The following is a description of a gene set: studied in species Mus musculus Mouse Gene Set: GOCC_CONTRACTILE_MUSCLE_FIBER Fibers, composed of actin, myosin, and associated proteins, found in cells of smooth or striated muscle., and this is the list of marker genes: Rpl17, Myl4 (myosin, light polypeptide 4), Flnc, Sqstm1, Ak1, Tmod3, Nos1ap, Krt8 (keratin 8), Alppl2, Kcnj8, Ggps1 (NCBI Gene Id 97873), Palld, Kcnn1, Cmya5, Vcl, Kcna5, Cacna1d, Myl1, Prkd1, Casq1, Smn1, Svil, S100a1, Rtl1, Fkbp1b, Nrap, Jph2, Scn1a, Cacna1c, Ilk, Actn4, Akap4, Mtmr12, Dmd, Pdlim3, Cfl2, Cst3, Actn3 (actinin alpha 3), Actc1, Ldb3, Tnnc2, Timp4, Frg1, Mybphl, Rem1, Flna, Fhod3, Myl7, Rpl6, Fhl5, Myh3, Acta1, Dek, Neb, Jph1, Polr2m, Sptan1, Cavin4, Scn3b, Tmod2, Trpc1, Ido1, Myh1, Tmod4, Gja1, Fkbp1a, Mybpc1, Myh13, Sri, Homer1, Capn3, Kcne1, Cacna1s, Kat2b (K(lysine) acetyltransferase 2B), Lrrc10, Pdlim4 (PDZ and LIM domain 4), Pdlim2, Des, Twf1, Myoz3, Ryr3, Asb2, Krt19, Myl12b, Pgm5, Tnnt3, Myl3, Casq2, Tnni2, Sphkap, Myoz1, Myh11, Pdlim5, Fbxl22, Tuft1, Pde4d, Slc4a1, Lmod2, Tcap, Myl2, Atp2b4, Tpm2, Fhl2, Acta2, Nebl, Ank1 (ankyrin 1, erythroid), Tnni3, Myom2, Bag3, Myo18b, Cab39, Mypn (myopalladin), Smtnl1 (NCBI Gene Id 68678, smoothelin-like 1), Myom1, Col6a1, Ppp1r12b, Psma6, Parva, Myl12a (myosin, light chain 12A, regulatory, non-sarcomeric), Dctn4, Cav3, Nbr1, Plec, Npnt, Sdc4, Trim63, Glrx3, Ank3, Syne1, Myh7b, Csrp3, Dag1, Rpl7, Fbxo22, Ablim2, Psen2, Actg1, Ttn, Scn5a (NCBI Gene Id 20271), Parvb, Ankrd2, Kbtbd13, Flnb, Actn2, Synpo2l, Pde4dip, Myh2, Sco1, Ppp1r12a, Grk3, Itgb1bp2, Calm1, Sorbs2, Tnnt2, Trim32, Fbp2, Nexn, Synm, Jup, Fhl3, Rpl15, Ryr1, Dnajb6, Cdk5r1, Ctnnb1, Ppp3ca, Kcnn2, Hdac4, Fermt2, Ppp2r5a, Igfn1, 3425401B19Rik, Slc2a1, Aldoa, Mybph, Twf2, Rtn2, Slmap, Hspb1, Dnajb4, Trim54, Lmod3, Csrp1, Nos1, Myl9, Pdlim1, Stub1, Sptbn1, Pecam1, Pdlim7, Actn1, Smpx, Bin1, Styxl2, Lman1, Myh6, Cryab, Myh8 (NCBI Gene Id 544790), Prickle4, Arf1, Slc8a1, Simc1, Myh7, Ankrd23, Myod1, Tjp1, Calm2, Rpl4, Klhl41, Fbxo32 (F-box protein 32), Obscn, Kcnn3, Myzap, Myh4, Abra, Tnni1, Adra1a, Stk11, Ryr2, Lrrc39, Myoz2, Ppp3cb, Arhgef25, Sco2 (SCO2 cytochrome c oxidase assembly protein), Pyroxd1, Csrp2, Mybpc3, Unc45b, Calm3, Fkrp, Tmod1, Mybpc2, Bmp10, Dst, Scn8a, Xirp2, Lmod1, Dbi, Tpm1, Myot, Mef2c, Habp4, Mmp2, Pak1, Tnnt1, Ky, Ank2, Atp2a1, Syne2, Synpo, Capzb, Hrc, Ankrd1, Myom3, Pgm1, Pygm, Anxa5, Synpo2, Abcc9, Adprhl1, Klhl40, Sync, Fxr1, Tnnc1, Grin2b, Kctd6, Mtm1